The following is a description of a gene set: studied in species Mus musculus Mouse Gene Set: GOBP_REGULATION_OF_INTERLEUKIN_18_PRODUCTION Any process that modulates the frequency, rate, or extent of interleukin-18 production., and this is the list of marker genes: Cd84 (CD84 antigen), Tlr9, Nlrp9b, Casp1, Nod2, Gbp5, Tnf, Usp50, Gsdmd, Tlr2, Dhx9